Given this list of marker genes STAT5A, STAT3, JAK3, STAT5B, ALK, here is a description of the gene set: Human Gene Set: KEGG_MEDICUS_VARIANT_EML4_ALK_FUSION_KINASE_TO_JAK_STAT_SIGNALING_PATHWAY Pathway Definition from KEGG: EML4-ALK -> JAK3 -> STAT3,STAT5 EML4-ALK fusion kinase to Jak-STAT signaling pathway. Pathway ID: N00105. Pathway type: Variant. Pathway class: nt06266 Non-small cell lung cancer. species: Homo sapiens